The following is a description of a gene set: from publication Payen D, Lukaszewicz AC (PMID 19535937) Human Gene Set: GSE9960_HEALTHY_VS_SEPSIS_PBMC_UP Genes up-regulated in peripheral blood monocytes (PMBC): healthy versus sepsis. species: Homo sapiens To identify signature genes that help distinguish (1) sepsis from non-infectious causes of systemic inflammatory response syndrome, (2) between Gram-positive and Gram-negative sepsis., and this is the list of marker genes: ATP6V0B, PSORS1C3, CHCHD2, RNASEH1-DT, CD276 (CD276 molecule), FKTN, TRAF3IP3, HSPA12A, TUBB4B, GOLGA3, DDX49, SOCS2, MMP10, TOP2A, NRIP3, PPP1R3B-DT, SRXN1 (sulfiredoxin 1), NUS1, CKLF, DSEL, MAGOH-DT, ABCB4, PIP5K1C, NDUFV2, RAD1, VAMP7, ABHD1, DIPK1B, IL1RAP, EGLN3, PYDC1, CDC45, SPRED2 (NCBI Gene Id 200734), MOB3B, GP1BA, MRPS16, HYAL3, PTPRF, GRPEL1, SMOX, BCL2L1, RHOF, MDP1, RTP3 (receptor transporter protein 3), SRPRA, LTA, IGSF8, MMP12, RNF41, PDCD6, GNPDA2, SCAMP3, C14orf119, CSPG4, KLHL15, PDE7B-AS1, MYO1E, HCCS (holocytochrome c synthase), PDZD2, GNAZ, PRKAG1, TIMM10B, EBF1 (EBF transcription factor 1), SHISA4, GRAMD1C, ARHGAP28, ARHGAP10, STEAP3, KLRB1, COX7A2L, TNC, MMP13, CHRNA1, HCAR3, MPHOSPH6, STEEP1, FADD, TNFSF14, HIPK2, ACTN1, RBPJ, MT1M, TNFSF18, ETHE1, GPR68, B4GALT3, METTL16, UFC1, MMP8, BRK1, PIM2, UBR4, PTGIS, PELP1, SLAMF9, SKA3, POLR2H, SCN4B (sodium voltage-gated channel beta subunit 4), PPFIA4, ZDHHC12, VSTM2L, RCC2, APC2, ZNF189, SPINT1, SGTA, CDKN3, SNU13, MRPL1, ODF1, HEPACAM2, DAD1, SPCS1, DCUN1D1, RFT1, VCX2, RASSF6, TXNDC17, UBE2I, PIGZ, EEF1A1, KCNK13, PTTG1, RHOQ, MGP (NCBI Gene Id 4256), C1orf210, PKM, TFPI, SLC28A3, TACO1, PROS1, MTO1, CREB5, CTPS1, LINC00226, NDUFA9, CSF1, MGC27382, JPT1, TUSC2, PRKD1, NT5E, GLRA3 (NCBI Gene Id 8001), PSMA8, PTCD1, SYDE2, LHB, BRDT, CNIH3, NBR2, NDUFC1, FOXA2, DNTTIP2, F3, SLC44A1, TMEM53, ADRA2B, NUDT22, ZCRB1, TNMD, HTN1, UNC119, RXYLT1, TMEM39A, STAC, ATP1A3 (NCBI Gene Id 95633), AFDN, PFDN1, UAP1, VAT1L, SLC3A2, ANKS3, KEAP1, CCDC167, CCDC7, CCL17, SPEM2, ELAPOR1, GNL3LP1, RAC3, COPS2, MTUS2-AS1, HOPX, LINC00612, OST4, NUP43, SERGEF, RANGRF, POLR1D, CCL24, ENTHD1, TNFAIP8L2, ITM2A, PDLIM7, KCTD1